Given this list of marker genes NEK2 (NIMA related kinase 2), HGH1, SLCO1A2, POU5F1P4, SHMT2, TXN2, NNT, HPGD (15-hydroxyprostaglandin dehydrogenase), RNF7, RPL39L, MGLL, AFF2, CXCL2, C3orf36, PPP1R11, SPSB3, EBI3, INSR, ALDH4A1, IL36G, MST1R, SLC25A3, COMMD4, ASB13, WDR45B, TFAP2C, ATP8B3, RNASE1, DKK3 (dickkopf WNT signaling pathway inhibitor 3), ZNF74, JAG1, TSPYL4, OPLAH, DIXDC1, SLC1A1, PDCD1LG2 (programmed cell death 1 ligand 2), MAPK11, TLR3, COL11A2, RPS15, B4GALT1, ELOVL5, CSF2, CUBN, WDTC1 (WD and tetratricopeptide repeats 1), CD93, NCK2, DUOX2, DNM2, CRYBG2 (NCBI Gene Id 647881), CELSR1, FOXN3, TEF, SAMD14, LY6H, NBAS, ITGB3, GDPD3, NEFH, MTSS2, UPK1B, MYH3, PDE12, LPGAT1, SIT1, SPATA7, TMEM8B, AGK, CHRM5, PPY2P, ARG2, MRPS10, APOL2, KCNQ2, ARL1, RAE1 (NCBI Gene Id 8480), EFS, GLTP, PTPN2, PLSCR3, CLIC3, CFAP74, RABGGTA, PARP2, LRRC49, SOX30, CCNK, KLF7, KCNJ6, ADAM7, CRISP3, NAALAD2, NPTX1, KCNB1, NUP205, HYAL2, WNT3, DELE1, CYLC1, STS (NCBI Gene Id 6802), SYNJ2BP, SPRY4, DRAM1, MMP10, PWP2, AP4S1, OSGIN2, PLXNB2, SLC43A3, AKR1B10, TMEM231, NTHL1 (nth like DNA glycosylase 1), CCL18, FGF18, SLC1A5, ACE, SLC14A2, GPR39, WDR77, NETO2, NCAPH, ORM1, RGS9, IMPA1, CYRIB, LPAR1 (NCBI Gene Id 1902), PCBD1, SSPN, CZIB, FBXL12, DDX31, COPS2, ITGB8, TOR3A, ZCCHC14, FXYD2, MYCNOS, FGFR4, GNB1L, SLAMF7, PRPSAP1, TMEM70, COL16A1 (collagen type XVI alpha 1 chain), LGR4, DOC2B, FAM174B, CTIF, SLC16A4, PEX12, PREP, CDS1, CD38, LSR, GCLM, TJP2 (NCBI Gene Id 9414), FCGR2A, L3MBTL1, CDKN2A, KCNC4, ZNF468, IGLL1, MYDGF, ANKMY1, PRKACA, TMEM135, CCDC106, MYH2, SCNN1B, MAST2, RBM38, SERPINB9, PTGS2, PIK3R4 (phosphoinositide-3-kinase regulatory subunit 4), PML, MS4A2, ZNF81, TAS2R14, PADI4, STIMATE, CABP1, BTC, SRRT, GCNT3, MAP6D1, CA11, PTPN3, IQCC, ABR, CST2, HACD3, USP6NL (USP6 N-terminal like), PLGRKT, PATZ1, MTARC2, SH2B3, here is a description of the gene set: Human Gene Set: GSE22611_NOD2_TRANSD_VS_CTRL_TRANSD_HEK293_MDP_STIM_6H_DN NOD2 is an intracellular receptor for the bacterial cell wall component muramyl dipeptide (MDP) and variants of NOD2 are associated with chronic inflammatory diseases of barrier organs e.g. Crohn disease, asthma and atopic eczema. It is known that activation of NOD2 induces a variety of inflammatory and antibacterial factors. The exact transcriptomal signatures that define the cellular programs downstream of NOD2 activation and the influence of the Crohn-associated variant L1007fsinsC are yet to be defined. To describe the MDP-induced activation program, we analyzed the transcriptomal reactions of isogenic HEK293 cells expressing NOD2wt or NOD2L1007fsinsC to stimulation with MDP. Importantly, a clear loss-of-function could be observed in the cells carrying the Crohn-associated variant L1007fsinsC, while the NOD2wt cells showed differential regulation of growth factors, chemokines and several antagonists of NF-κB, e.g. TNFAIP3 (A20) and IER3. from publication Billmann-Born S, Till A, Arlt A, Lipinski S, Sina C, Latiano A, Annese V, Häsler R, Kerick M, Manke T, Seegert D, Hanidu A, Schäfer H, van Heel D, Li J, Schreiber S, Rosenstiel P (PMID 21335489) Genes down-regulated in HEK293 cells at 6h after stimulation by muramyl dipeptide: over-expressing wildtype NOD2 versus control. species: Homo sapiens